The following is a description of a gene set: RHO GTPases activate CIT Human Gene Set: REACTOME_RHO_GTPASES_ACTIVATE_CIT studied in species Homo sapiens, and this is the list of marker genes: RHOC, MYH10, MYH9 (NCBI Gene Id 65212), MYL6, PPP1R12A, CDKN1B, RAC1, KIF14, PPP1R12B, PRC1, MYL12B (myosin light chain 12B), PPP1CB, CIT, MYH11, RHOB, MYL9, RHOA, MYH14, DLG4